The following is a description of a gene set: species: Mus musculus Any process that decreases the rate, frequency, or extent of cholesterol metabolism, the chemical reactions and pathways involving cholesterol, cholest-5-en-3 beta-ol, the principal sterol of vertebrates and the precursor of many steroids, including bile acids and steroid hormones. Mouse Gene Set: GOBP_NEGATIVE_REGULATION_OF_CHOLESTEROL_METABOLIC_PROCESS, and this is the list of marker genes: Erlin2, Insig1 (insulin induced gene 1), Erlin1, Ch25h, Sod1, Apoe, 3110082I17Rik, Idi2